Given this list of marker genes Orc3, Gmnn, Mcm7, Mcm2, Psmd7, Orc1, Psmd13 (proteasome (prosome, macropain) 26S subunit, non-ATPase, 13), Psma3, Pola2, Anapc7, Cdc6, Orc4, Cdc26, Mcm4, Ube2d1, Psma5, Psmd12, Anapc2, Kpna6, Psmb5, Psma2, Pole, Psma1, Psmc4, Psmc6, Psmd6, Pola1, Mcm8, Rpa1, Kpna1, Orc5, Fzr1, Cdc7, Anapc15, Ube2s, Psma4, Psma7, Prim1, Anapc10, Psmb6, Psmd1, Pole2, Psmb7, Psmc3, Cdc23, Ube2c, Dbf4, Psmb4, Psmc1 (NCBI Gene Id 19179), Rps27a, Cdc45, Psmc5, Kpnb1, Ube2e1, Psma6, Ubb, Psmc2, here is a description of the gene set: This event has been computationally inferred from an event that has been demonstrated in another species.<p>The inference is based on the homology mapping from PANTHER. Briefly, reactions for which all involved PhysicalEntities (in input, output and catalyst) have a mapped orthologue/paralogue (for complexes at least 75% of components must have a mapping) are inferred to the other species. studied in species Mus musculus part of: DNA Replication Reactome Pathway: DNA Replication Pre-Initiation electronically inferred by orthology from the curated human pathway